The following is a description of a gene set: species: Homo sapiens part of: RHO GTPase cycle This pathway catalogues RHOG guanine nucleotide exchange factors (GEFs), GTPase activator proteins (GAPs), GDP dissociation inhibitors (GDIs) and RHOG effectors. RHOG is a RAC-related RHO GTPase, ~70% identical to RAC1. RHOG is broadly expressed in different tissue types. It regulates the cytoskeleton, acting either upstream of or in parallel to RAC1. RHOG regulates cell polarity, adhesion, migration and invasion, contributing to the formation of lamellipodia and invadopodia. The ortholog of RHOG is required for neuronal development in C. elegans (de Curtis 2008). RHOG is involved in VEGF signaling and angiogenesis (El Baba et al. 2020). RHOG cooperates with RAC1 and CDC42 in malignant cell transformation and may contribute to invasiveness of cancer cells. Reactome Pathway: RHOG GTPase cycle, and this is the list of marker genes: ARHGEF5, ARHGEF26, VAV1, VANGL1, EPHA2, KALRN, MCF2L, TRIO, CAV1, NDUFA5, PAK2, ARHGAP32, EMD, CDC42EP1, ERBIN, ARHGAP35, DSG2, CDC42, DOCK5, ESYT1, ARFGAP3, DOCK1, DOCK2 (NCBI Gene Id 1794), LMAN1, ARHGAP39, MPP7, ARHGAP5, HSPE1, ELMO2, CYFIP1, MCAM, DOCK3, VAMP3, ARHGAP21, STX5, PREX1, ARHGDIB (NCBI Gene Id 397), MAP3K11, ANKLE2, LBR, PIK3R1, DEPDC1B, IQGAP2, ARHGDIA, VRK2, STBD1, TFRC, ITSN1, VAPB, VAV3, RHOG, VAV2, MCF2, OPHN1 (oligophrenin 1), DOCK4, ARHGDIG, ARHGEF16 (NCBI Gene Id 27237), LAMTOR1, LEMD3, PGRMC2, RAB7A, KTN1, LETM1, SHMT2, PLEKHG3, GARRE1, PAK4, TMPO, YKT6, PLD1, ARHGAP1, DIAPH3, ITGB1, NDUFS3